Given this list of marker genes GATA2 (NCBI Gene Id 84724), SMAD1, TGFB1, NOTCH3, FOSL1, IL10, NOTCH2, MRTFB, MYC, HOTTIP, NR1H2 (NCBI Gene Id 7376), NEAT1, HRAS, SREBF1, MALAT1, RELA, TEAD1, TERT, GNL3, NR3C1, MYB, TNF, SMAD6 (NCBI Gene Id 4091), EGFR, BMPR1A, LIN28B (NCBI Gene Id 389421), NFKB1, NGFR, HIF1A, WT1, XIST, EGR1, AGT, PNPT1, PRL, TGFB2, MYOCD, PPARG, POU2F1, AR, PAX6, PDGFB, ETS1, ATOH8, FGF2, SRF, FOXO3, SMAD4, SREBF2, MRTFA, IL6, STAT3, JUN, MYCN, ZC3H12A, FOS, KLF4, GATA3, DNM3OS, SPI1, SMAD3, APLN, ZSWIM8, BMP2, TP53, SMARCA4 (SWI/SNF related, matrix associated, actin dependent regulator of chromatin, subfamily a, member 4), FOXA1, here is a description of the gene set: studied in species Homo sapiens Human Gene Set: GOBP_POSITIVE_REGULATION_OF_MIRNA_METABOLIC_PROCESS Any process that activates or increases the frequency, rate or extent of miRNA metabolic process.